The following is a description of a gene set: studied in species Mus musculus Genes positively differentially expressed in cell type: Treg upon treatment with cytokine: CD40L in mouse lymph nodes in vivo. Mouse Gene Set: CUI_TREG_CD40L_RESPONSE_UP from publication Cui A, Huang T, Li S, Ma A, Pérez JL, Sander C, Keskin DB, Wu CJ, Fraenkel E, Hacohen N (PMID 38057668) Cytokines mediate cell-cell communication in the immune system and represent important therapeutic targets. A myriad of studies have highlighted their central role in immune function, yet we lack a global view of the cellular responses of each immune cell type to each cytokine. To address this gap, the authors created the Immune Dictionary, a compendium of single-cell transcriptomic profiles of more than 17 immune cell types in response to each of 86 cytokines (>1,400 cytokine-cell type combinations) in mouse lymph nodes in vivo. A cytokine-centric view of the dictionary revealed that most cytokines induce highly cell-type-specific responses. For example, the inflammatory cytokine interleukin-1β induces distinct gene programmes in almost every cell type. A cell-type-centric view of the dictionary identified more than 66 cytokine-driven cellular polarization states across immune cell types, including previously uncharacterized states such as an interleukin-18-induced polyfunctional natural killer cell state., and this is the list of marker genes: Gt(ROSA)26Sor, Tfe3, Rasal3, Cfl1, Sell, Psmc4, Pfn1